Given this list of marker genes Acsm5, Glyatl3, Acsm1, Acsm2, Acsm4, here is a description of the gene set: This event has been computationally inferred from an event that has been demonstrated in another species.<p>The inference is based on the homology mapping from PANTHER. Briefly, reactions for which all involved PhysicalEntities (in input, output and catalyst) have a mapped orthologue/paralogue (for complexes at least 75% of components must have a mapping) are inferred to the other species. studied in species Mus musculus part of: Phase II - Conjugation of compounds electronically inferred by orthology from the curated human pathway Reactome Pathway: Amino Acid conjugation